The following is a description of a gene set: Phosphorylation of Emi1 species: Homo sapiens Human Gene Set: REACTOME_PHOSPHORYLATION_OF_EMI1, and this is the list of marker genes: CDK1, FZR1, CDC20, FBXO5, PLK1, CCNB1